The following is a description of a gene set: species: Mus musculus from publication Hoffmann R, Seidl T, Neeb M, Rolink A, Melchers F (PMID 11779835) Gene expression profiles of five consecutive stages of mouse B cell development were generated with high-density oligonucleotide arrays from as few as 2 x 10(4) ex vivo isolated and flow-cytometrically purified cells. Between 2.8% and 6.8% of all genes change on differentiation from one cellular stage to the next by at least twofold. The entire pathway involves differential expression of 10.7% of all genes. Previously known expression patterns of genes (like surrogate light chain, RAG-1/2, MHC class II, mel-14 antigen) are confirmed. The gene expression patterns of the proliferating pre-BI and large pre-BII cells on the one hand, and the resting immature and mature B cells on the other hand, are most similar to each other. Small pre-BII cells display a pattern that is transitional between these two groups. Most of the genes expressed in early precursors are involved in general processes, like protein folding or cell cycle regulation, whereas more mature precursors express genes involved in more specific molecular programs (cell surface receptors, secreted factors, and adhesion molecules, among others). Between 19 and genes share a given expression pattern. Combining knowledge about gene function and expression pattern allows identification of novel candidate genes potentially involved in self-maintenance of pre-BI cells, allelic exclusion and pre-B cell receptor signaling in large pre BII cells, cell-cycle arrest of small pre-BII cells, propensity toward apoptosis or anergization in immature B cells, propensity toward cell division and activation in mature B cells, and stage-specific interactions with stromal cells in the bone marrow. Human Gene Set: HOFFMANN_SMALL_PRE_BII_TO_IMMATURE_B_LYMPHOCYTE_UP Genes up-regulated during differentiation from small pre-BII to immature B lymphocyte., and this is the list of marker genes: CD36, NLRP6, ZNF708, CCND2, APOC3, CD74, VEGFB, MAPK8IP3, MYOG, SERPINB1, PLD4, SIPA1, SEMA4D, ICAM1, SDC4, XPO1, ZFP1, HLA-DMB, CNR2 (NCBI Gene Id 1269), GIMAP4, EHD1, CD83, PSAT1, CXCR5, PRTN3, IGKV1D-43, SCD, HLA-DRB1, LAT2, HOXC5, HLA-DQB1, DAD1 (NCBI Gene Id 1603), CD22 (CD22 molecule), SUCLG2, ISYNA1, MFHAS1, IL4I1, ACY1, FCER2, NCF4, NEDD4, SLC2A3, RBMS2, MYBBP1A, IFI30, LEFTY1, ABHD14A, TRAPPC5, PRPS1, HMBS, HLA-DMA, LHB, FES, ZNF385A, HLA-DQA2, MYH11, MECOM, CFP, MS4A1, MEF2C, HES1, FLII, PEPD, LTB (lymphotoxin beta), CTSH (NCBI Gene Id 1512), GGA2